The following is a description of a gene set: species: Homo sapiens A type of reduced stature with normal proportions related to dysfunction of the pituitary gland related to either an isolated defect in the secretion of growth hormone or to panhypopituitarism, i.e., a deficit of all the anterior pituitary hormones. Human Gene Set: HP_PITUITARY_DWARFISM Pituitary dwarfism, and this is the list of marker genes: PROP1, LHX3, FOXA2, LHX4, GH1, GLI2, OTX2, POU1F1, SOX3 (SRY-box transcription factor 3), HESX1